The following is a description of a gene set: species: Homo sapiens Antigen activates B Cell Receptor (BCR) leading to generation of second messengers Human Gene Set: REACTOME_ANTIGEN_ACTIVATES_B_CELL_RECEPTOR_BCR_LEADING_TO_GENERATION_OF_SECOND_MESSENGERS, and this is the list of marker genes: IGHV1-69, PIK3R1, AHCYL1, CD19, IGKV3-11, IGKV1D-16, IGKV2-30, IGKV2D-40, CD79A, IGLV1-51, IGLV2-8, TRPC1, ITPR1, IGKV2D-30, IGHV4-39, STIM1, IGHV3-13, IGHV3-53, IGHV1-2, IGLV3-27, PIK3AP1, ITPR2, IGKV1-39, BLK, IGHV3-11, CD22, BLNK, PTPN6, FYN, IGKV4-1, IGKV1D-12, IGLV2-14, BTK, IGLV3-19, IGKV3-15, IGKV1D-39, IGLV7-43, IGHV3-48, IGLC3, IGHV3-7, IGKV1-17, IGLV3-21, IGKV2-28, IGHD, IGKV2D-28, IGHV2-5, IGKV1-33, IGLV6-57, DAPP1, IGKV1-16, IGHV3-23, VAV1, IGLV1-40, IGKV5-2, IGLV3-25, IGHV4-34, IGLV2-23 (NCBI Gene Id 28813), IGKV3D-20, IGHM, IGKV1-5, IGLC2, IGHV2-70, IGHV3-30, SH3KBP1, ORAI2, ORAI1 (ORAI calcium release-activated calcium modulator 1), IGLV1-44, IGHV3-33, GRB2, IGHV4-59, CALM1, IGKV3-20, IGLV1-47, PLCG2, NCK1, SYK, IGHV1-46, IGKV1D-33, SOS1, PIK3CD, CD79B, ITPR3, IGKV1-12, IGLV2-11, LYN (NCBI Gene Id 4067), IGLV3-1